The following is a description of a gene set: Any functional anomaly of the liver. Abnormal liver physiology Human Gene Set: HP_ABNORMAL_LIVER_PHYSIOLOGY studied in species Homo sapiens, and this is the list of marker genes: IARS1, SLC25A13 (solute carrier family 25 member 13), SC5D, SLC51A, AKR1D1, CYP7B1, PEX14, AMACR (NCBI Gene Id 23600), AP1S1, PKHD1, TJP2, VPS50, ALMS1, HSD3B7, ABCB11 (NCBI Gene Id 8647), HBB, UBR1, FOCAD, SLC2A2, ATP8B1, ZFYVE19, AP1B1 (NCBI Gene Id 162), ASAH1, MPV17, ABCB4, PGM1, FH